The following is a description of a gene set: studied in species Homo sapiens The binding of an endothelial cell to the extracellular matrix via adhesion molecules. Human Gene Set: GOBP_ENDOTHELIAL_CELL_MATRIX_ADHESION, and this is the list of marker genes: ADAMTS9, PLPP3, MIR92A1, FUT1, LEF1, GFUS, RIN2, RRAS, CEACAM6, PECAM1, MMP12